Given this list of marker genes Hip1r, Hip1, Dab2, Golph3l, Ap1m1, Ap2a2, Ap1g2, Ldlrap1, Ap2a1, Ap1s1, Ston2, Ap1m2, Snap91, Ap2m1, Ston1, Ap2s1, Golph3, Arrb1, Epn1, Ap1s2, Ap4e1, Ap1s3, Ap1g1, here is a description of the gene set: studied in species Mus musculus Binding directly to the structural scaffolding elements of a vesicle coat (such as clathrin or COPII), and bridging the membrane, cargo receptor, and membrane deformation machinery. Mouse Gene Set: GOMF_CARGO_ADAPTOR_ACTIVITY